Given this list of marker genes COQ2, LPIN1, MT-CO1, OBSCN, HADHB, MT-CO3, PYGM, here is a description of the gene set: species: Homo sapiens Recurrent myoglobinuria Recurring episodes of myoglobinuria, i.e., of the presence of myoglobin in the urine. This is usually a consequence of rhabdomyolysis, i.e., of the destruction of muscle tissue. Human Gene Set: HP_RECURRENT_MYOGLOBINURIA